Given this list of marker genes Dlg4, Gria2, Grin1, Calm3, Grin2c, Grin2a, Dlg2, Lrrc7, Gria3, Gria4, Camk2d, Grin2d, Dlg3, Camk2a, Calm1, Camk2b, Dlg1, Nefl, Calm2, Gria1, Actn2, Camk2g, here is a description of the gene set: studied in species Mus musculus Unblocking of NMDA receptors, glutamate binding and activation Mouse Gene Set: REACTOME_UNBLOCKING_OF_NMDA_RECEPTORS_GLUTAMATE_BINDING_AND_ACTIVATION